Given this list of marker genes SLC25A12, PER2, SLC1A4, SLC1A3, NTSR1, TTYH3, SLC1A2, SLC25A13, PSEN1, SEPTIN2 (septin 2), KCNJ10, ARL6IP1, TTYH1, SLC25A22, GRM1, PRAF2, SLC17A6, SLC1A6, SLC3A1, SLC7A11 (NCBI Gene Id 23657), SLC25A18, TNF, SLC17A8 (solute carrier family 17 member 8), ARL6IP5, SLC17A7, SLC38A6, SLC7A13, CLN8, TTYH2, EPM2A, SLC1A7, SLC1A1, ITGB1, ATP1A2, here is a description of the gene set: studied in species Homo sapiens The directed movement of L-glutamate across a membrane by means of some agent such as a transporter or a pore. Human Gene Set: GOBP_L_GLUTAMATE_TRANSMEMBRANE_TRANSPORT